The following is a description of a gene set: species: Homo sapiens Any process that stops, prevents or reduces the rate or extent of mammary gland epithelial cell proliferation. Human Gene Set: GOBP_NEGATIVE_REGULATION_OF_MAMMARY_GLAND_EPITHELIAL_CELL_PROLIFERATION, and this is the list of marker genes: ROBO1, GATA3, CDKN2A, PHB2, BRCA2